Given this list of marker genes CTNNB1, MMP12, RPA3, ARFIP1, RUSC1, BCL3, MSC, ZFP36, TPD52, HBEGF, CD38 (CD38 molecule), NCLN, STOM, PYGM, ETHE1, UCP2, VAMP5, PSME2, NALF1, KIAA0586, TM4SF1, GBP1, PLCH2, COX10, CXCR4, CETN2, CKAP4, SERPINE1, CXCL8, GPR12, RNFT2, NUP58, PLOD2, MT1B, CXCL1, HOXC5, OSBPL8, ASMTL, CXCL2, INPP4B, IGFBP7, SVEP1, TXNIP, OVOL3, CD1D, AURKA, KTN1, TNC, CCL8, LLGL2, FOSL2, TRPC4AP, KCNF1, HNRNPH3 (heterogeneous nuclear ribonucleoprotein H3), VCAN, PHC2, CSRP1, CAP1, NQO1, FSCN2, RUNX1, MCC, ATXN3, APOBEC3F, MUC6, PKP3, HTR1B, DLEC1, MMP14, KRT6A, P4HA2, RGS2 (regulator of G protein signaling 2), TUBB7P, DVL3, CEACAM7, PPP2R5D, NPEPPS, IRF1, PTEN, MMP1, LAMB3, ZNF189, SOCS1, CYP1B1, INPP5B, REM1, CXCL9, PDE4D, WDR43, SIT1, ENPP2, MTF1, AIM2, NDUFS1, CLOCK, SFMBT1, GLIPR1, KYNU, SSB, PTPN2, KHDRBS3 (KH RNA binding domain containing, signal transduction associated 3), PSMB9, TNR, CS, ACE (NCBI Gene Id 654142), MAPK8, SERPINB1, CILK1, ALPI, SREK1IP1, PPWD1, RALA (RAS like proto-oncogene A), RELA, PDE4B, SLC39A8, ACSL1, MT1X, HTRA1, DNM1L, FKTN, GRIK5, SNRPA1, IQSEC2, SLC2A3 (solute carrier family 2 member 3), MT1F, SLC4A7, ZNF44, CD70, LILRB2 (leukocyte immunoglobulin like receptor B2), OLR1, GOLGA8A, NAMPT, SLC30A4, PDK1, PTPRCAP, GSK3B, TIMP1, GBP2, RGS16, ARR3, DDIT4, ZNF638, TNFAIP6, FABP4, TUBA1A, STEAP1, MAGEA12, TPGS2, AMHR2, PBX2, CXCL11, SLC25A16, CYP2B7P, CCR5, MT1G, CLK1, TNFAIP3 (NCBI Gene Id 7128), TSC22D3, SEPTIN11, VEGFA, IL7R, THEMIS2, MCL1, VASP, PLIN2, EPB41L3, KIF5C, GYS1, SREK1, GLUL, RCN2, ZFP36L1, ANPEP, ADCYAP1R1, SRGN, SPTAN1, BCL2A1, STK3, RNASE2, CCSER2, RAB31, HLF, PTGS2 (NCBI Gene Id 5743), TM9SF1, IDO1, SCG5, SLC31A1, H4C3, IL3RA, ARSB, TSFM, KAT2B, CCL20, CAPN7, MIR483, BICDL1, AQP9, TLR2, NME1, here is a description of the gene set: from publication Chaussabel D, Semnani RT, McDowell MA, Sacks D, Sher A, Nutman TB (PMID 12663451) studied in species Homo sapiens Genes down-regulated in comparison of macrophages exposed to 50 worms/well B. malayi versus macrophages exposed to M. tuberculosis. Monocyte-derived dendritic cells (DC) and macrophages (MΦ) generated in vitro from the same individual blood donors were exposed to five different pathogens, and gene expression profiles were assessed by microarray analysis. Responses to Mycobacterium tuberculosis and to phylogenetically distinct protozoan (Leishmania major, L. donovani, Toxoplasma gondii) and helminth (Brugia malayi) parasites were examined, each of which produces chronic infections in humans yet vary considerably in the nature of the immune responses they trigger. Human Gene Set: GSE360_HIGH_DOSE_B_MALAYI_VS_M_TUBERCULOSIS_MAC_DN